Given this list of marker genes NSMAF, SMPD2, SMPD3, TNF, RACK1, TNFRSF1A, here is a description of the gene set: Human Gene Set: REACTOME_TNFR1_MEDIATED_CERAMIDE_PRODUCTION TNFR1-mediated ceramide production species: Homo sapiens